Given this list of marker genes MBD2, SLC6A13, CYBA, BTG2, KAT6B, IRAK4, BASP1, IGHV3-72, POU2AF1, ITIH3, BCL2, LRRC36, ZSWIM8-AS1, APOA2, PTGDR2, CNR1, RMDN1, LZTS1, JCHAIN, NOS1, SEC14L4, DKFZP434A062, IGHV3-23, DTNB-AS1, AOX1, IFT70A, ZNF473, CSNK2A1, IDH3A, YWHAH-AS1, SPCS3, ZBTB25, VPS13D, WBP11, PAX5 (NCBI Gene Id 5079), ISG20, CACNA1A, IRAK3, CAMKMT, MAGOH2P, COMMD3, IL5RA, SLC35E3, ANKRD36B (NCBI Gene Id 80265), ZFYVE9, ELF5, IGHG1, RFPL3, MANF, EFEMP2, TXNDC15, ZER1, KRT81, NANS, ARHGAP17, PPT2, SAA1, STXBP6 (syntaxin binding protein 6), MYL10 (myosin light chain 10), COL9A3, ARTN, KLK6 (kallikrein related peptidase 6), NMNAT2, PTPN2, SLC26A4, SOX10, ZC3H13, RHAG, OGDHL, CACNA1F, CMA1, TCP10L (NCBI Gene Id 55264), LIME1, DIP2C, IGHM, PPY, NXPH4, RABAC1, NCR1, CD19 (NCBI Gene Id 930), RHOQ, ALAS2, SSR4, ATP6V0A1, RRP9, SNN, SRF, RHOH, PAK3, NLE1 (notchless homolog 1), PAOX, VPREB1, L1CAM, BRME1, IGKV1OR1-1, ISOC2, SLC38A7, ZNF419, HES2, FKBP11, OGFRL1, PRDM1, LDOC1, KCNJ4, GPER1, TP63, ERP44, GJA3 (NCBI Gene Id 2700), MRPS31, ADGRG6, ITM2C, ASCL3, GAS8-AS1 (GAS8 antisense RNA 1), DCAF1 (NCBI Gene Id 9730), GABRR1 (NCBI Gene Id 2569), UMOD, FKBP1B, SSR3, CHST2, SLC2A5, TRGC1, THEMIS2, GH1, IGKV2D-28, FAM30A, FCRL2, IGKV4-1, TCL1B, NR1I2, ORAI2, CFB, TPSG1, DRD4, FFAR2, CENPT, TAPBPL, THRA, TRAM2, SPPL2B, MAST1, IGHV3-73, IGLL3P, SPANXA1, TRBV16, MAP2K7, CD79A, GATA2, CD300A, IGHV1-69 (immunoglobulin heavy variable 1-69), HERPUD1, ICAM2, CRYBB3, TFAP2A, DLG4, ABCC3, IGKV1OR2-108, SEC24A, CDC42EP2, CSH1, CYP2E1, SH3D21, KIR3DL2, LRRC41, SLC22A2, CD180, MGAT2, ACRV1, MAVS, CD38, DERL1, NCR3, IGKV1D-39, C1RL, PROZ, NPEPL1, PNOC, MED13L, TRIM31, HGH1, PLA2G2A, TCL1A, SRRM1, RAB26, IGKC, FRMD1, SPAG4, TPP1, SPATS2L, ADORA2A, ZNF215, KIZ, HSPA13, CRISP1, NF1, SOD2, IGHV3-47, PDK1, IGLC2, DLL3, IGHV4-34, HSF2BP, OXCT1, TNIP3, SERPINB4, IRF4, DPYSL4, MMP14, TRIM26, ICAM3, NSG1, EPS15L1, IGLV3-19, SMIM27, ARHGAP45, ZBP1, AMN, NEU2, SOX14, CEP135, ADORA3, GCKR, ENDOU, DENND5B, BBOX1, KCNN3, TRGV5P (NCBI Gene Id 6979), SH3BP2, IGHV3-21, ABCA12, CYTIP, HPD, PIM2, ITGB4, WBP4, IFNA10, IGHV3-20, TTLL4, IGHV4-61, AQP6, GJD2, GZMB, C21orf91, SLC12A3, UBE2J1, SIGLEC5, EAF2, MSX2, ADGRD2, SAA3P, SEC14L1, SLC1A1, IGKV1D-37, DNAJB9, NEBL, ATP2A3, PRDX4, SLC1A4, TXNDC5, NPPC, CHST11, IGHV3-7, CCND2, CRADD, TCP11L1, KCNJ14, SSX2, IGHA1, GAST, PRMT2, SLAMF7, TNFRSF6B, SLC43A1, IGHV3-33, DAZ1, ADAMDEC1, GRWD1, APOBEC3F, FGF12, PLXDC1, NCK1, SEL1L, BBIP1, DIPK1A, DMXL2, IGKV3-20, PPBPP2, LAX1, SCT, IGKV1D-17, RYBP, C1QL1, GPR31, NXPH3, N4BP1, TENT5C, ST6GAL1, ADCY9, DTX3, ATF5, TRAPPC9, FER1L4, IGHD, MED1, CPLX3, SERPINB3, TMCO3, SKAP1 (NCBI Gene Id 8631), DNAJC1, DCAKD, PCYT1B, IFNAR2, ITFG2 (integrin alpha FG-GAP repeat containing 2), VCPIP1, PGLYRP1, IGKV1D-13, SEL1L3, TNFRSF17, here is a description of the gene set: studied in species Homo sapiens Cluster 12 of method A: up-regulation of these genes in patients with non-small cell lung cancer (NSCLC) predicts good survival outcome. Human Gene Set: SHEDDEN_LUNG_CANCER_GOOD_SURVIVAL_A12 from publication Director's Challenge Consortium for the Molecular Classification of Lung Adenocarcinoma, Shedden K, Taylor JM, Enkemann SA, Tsao MS, Yeatman TJ, Gerald WL, Eschrich S, Jurisica I, Giordano TJ, Misek DE, Chang AC, Zhu CQ, Strumpf D, Hanash S, Shepherd FA, Ding K, Seymour L, Naoki K, Pennell N, Weir B, Verhaak R, Ladd-Acosta C, Golub T, Gruidl M, Sharma A, Szoke J, Zakowski M, Rusch V, Kris M, Viale A, Motoi N, Travis W, Conley B, Seshan VE, Meyerson M, Kuick R, Dobbin KK, Lively T, Jacobson JW, Beer DG (PMID 18641660) Although prognostic gene expression signatures for survival in early-stage lung cancer have been proposed, for clinical application, it is critical to establish their performance across different subject populations and in different laboratories. Here we report a large, training-testing, multi-site, blinded validation study to characterize the performance of several prognostic models based on gene expression for 442 lung adenocarcinomas. The hypotheses proposed examined whether microarray measurements of gene expression either alone or combined with basic clinical covariates (stage, age, sex) could be used to predict overall survival in lung cancer subjects. Several models examined produced risk scores that substantially correlated with actual subject outcome. Most methods performed better with clinical data, supporting the combined use of clinical and molecular information when building prognostic models for early-stage lung cancer. This study also provides the largest available set of microarray data with extensive pathological and clinical annotation for lung adenocarcinomas.